Given this list of marker genes Adcy6, Plcb1, Scnn1a, Scnn1b, Rangap1, Scnn1g, here is a description of the gene set: Mouse Gene Set: GOBP_RESPONSE_TO_VASOPRESSIN Any process that results in a change in state or activity of a cell or an organism (in terms of movement, secretion, enzyme production, gene expression, etc.) as a result of a vasopressin stimulus. species: Mus musculus